The following is a description of a gene set: studied in species Homo sapiens The uptake of L-glutamate by neurons or glial cells. This process leads to inactivation and recycling of neurotransmitters. Human Gene Set: GOBP_GLUTAMATE_REUPTAKE, and this is the list of marker genes: SLC17A8, CLN8, ITGB1, ATP1A2, PER2, KCNJ10